Given this list of marker genes Abcb11, Cyp7a1, Akr1c14, Baat, Slc27a2, Akr1c6, Nr1h4, Akr1d1, Akr1c18, Slc27a5, Acot8, Akr1c21, Acox2, Cyp8b1, Akr1c13, Akr1c20, Ncoa1, Amacr, Hsd17b4, here is a description of the gene set: electronically inferred by orthology from the curated human pathway part of: Synthesis of bile acids and bile salts Reactome Pathway: Synthesis of bile acids and bile salts via 7alpha-hydroxycholesterol studied in species Mus musculus This event has been computationally inferred from an event that has been demonstrated in another species.<p>The inference is based on the homology mapping from PANTHER. Briefly, reactions for which all involved PhysicalEntities (in input, output and catalyst) have a mapped orthologue/paralogue (for complexes at least 75% of components must have a mapping) are inferred to the other species.